Given this list of marker genes SLC7A14, SLC1A3, TTYH1, ITGB1, ARL6IP5, STXBP1, KCNJ10, ADORA1, ATP1A2, ARL6IP1, GNAT2, SLC38A6, SYT4, SLC12A2, SLC6A6, KCNJ8, TNF, SEPTIN2, AVPR1A, SLC1A1, SLC25A12, SLC25A13, DTNBP1, APBA1, SLC1A2, NPY5R, PER2, KMO, BEST1, SLC6A1, TRH, PRKG1, GRM1, KCNK1, SLC3A1, PSEN1, SLC1A4, CLN8, SLC7A11 (NCBI Gene Id 23657), TTYH2, SLC25A22, GRM2, NF1, TTYH3, SLC17A7, SLC7A13, NHERF1, SLC38A2, SLC17A8, P2RX7, PRAF2, SLC25A18 (solute carrier family 25 member 18), ABCC8, SLC1A7, ABAT, RAB3GAP1, GRM7, PIANP, GABBR1 (NCBI Gene Id 2550), VPS54, KCNK2, SLC32A1 (NCBI Gene Id 140679), ADORA2A, SNCA, EPM2A (EPM2A glucan phosphatase, laforin), GJA1, NTRK2, SLC6A13, AVP, SLC17A6, SLC1A6, NTSR1, GIPC1, here is a description of the gene set: species: Homo sapiens The directed movement of acidic amino acids, amino acids with a pH below 7, into, out of or within a cell, or between cells, by means of some agent such as a transporter or pore. Human Gene Set: GOBP_ACIDIC_AMINO_ACID_TRANSPORT